The following is a description of a gene set: from publication Chen Y, Wang X (PMID 31504780) studied in species Homo sapiens Human Gene Set: MIR4538 Genes predicted to be targets of miRBase v22 microRNA hsa-miR-4538 in miRDB v6.0 with MirTarget v4 prediction scores > 80 (high confidence targets)., and this is the list of marker genes: ZBTB7B, E2F3 (E2F transcription factor 3), SLC7A14, AZIN1, RELN, BHLHE40, WDR26, TMEM117, LRFN3, ZNF761, RPGR, CCDC179, PPP4R4, ARPC2, PLPP3, TMED7, RERE, TTN (titin), LRRC55, FNDC3B, SUB1 (SUB1 regulator of transcription), GK5, CCT6A, PDCD6IP, PRX, ASB4, RPF2